The following is a description of a gene set: species: Homo sapiens Arsenic to electron transfer in complex IV. Pathway ID: N01394. Pathway type: Env factor. Pathway class: nt06252 Mitochondrial ROS formation. Pathway Definition from KEGG: As -- AS3MT >> GSTO1 -> MMA -| CxIV Human Gene Set: KEGG_MEDICUS_ENV_FACTOR_ARSENIC_TO_ELECTRON_TRANSFER_IN_COMPLEX_IV, and this is the list of marker genes: AS3MT, COX5B, GSTO1, COX8C, MT-CO3, COX4I2, COX5A, COX6A1, COX7B (cytochrome c oxidase subunit 7B), COX8A, COX6A2, COX7A2L, COX6C, COX4I1, MT-CO2, COX7C (cytochrome c oxidase subunit 7C), COX7A1, MT-CO1, COX6B1, COX7A2, COX6B2